The following is a description of a gene set: This event has been computationally inferred from an event that has been demonstrated in another species.<p>The inference is based on the homology mapping from PANTHER. Briefly, reactions for which all involved PhysicalEntities (in input, output and catalyst) have a mapped orthologue/paralogue (for complexes at least 75% of components must have a mapping) are inferred to the other species. species: Mus musculus electronically inferred by orthology from the curated human pathway Reactome Pathway: Biosynthesis of EPA-derived SPMs part of: Biosynthesis of specialized proresolving mediators (SPMs), and this is the list of marker genes: Gpx4, Alox15, Lta4h, Ptgs2 (NCBI Gene Id 19225)